Given this list of marker genes Park7, Npy, Sult1a1, Drd1, Htr1a, Tgfb2, Sncb, Pde1b (phosphodiesterase 1B, Ca2+-calmodulin dependent), Drd2, Dbh, Drd4, Ndufs4, Epas1 (endothelial PAS domain protein 1), Comt, Snca, Moxd1, Spr, Agtr1a, Maob, Atp7a, Gnat2, Myo5a, Pnkd, Cyp2d22, Moxd2, Abat (4-aminobutyrate aminotransferase), Grin2a, Agtr2, Chrnb2, Aldh2, Hprt1, Vps35, Nr4a2, Itgam, Tacr3, Slc6a3, Gpr37, Dao, Ddc, Maoa, Rnls, Th, Slc1a1, Prkn, Gch1, Npr1, Sncaip, Mdga1, Htr2c, Tomt, here is a description of the gene set: The chemical reactions and pathways involving dopamine, a catecholamine neurotransmitter and a metabolic precursor of noradrenaline and adrenaline. species: Mus musculus Mouse Gene Set: GOBP_DOPAMINE_METABOLIC_PROCESS